The following is a description of a gene set: species: Mus musculus Mouse Gene Set: GOBP_REGULATION_OF_SYNAPTIC_PLASTICITY A process that modulates synaptic plasticity, the ability of synapses to change as circumstances require. They may alter function, such as increasing or decreasing their sensitivity, or they may increase or decrease in actual numbers., and this is the list of marker genes: Shisa6 (NCBI Gene Id 380702), Mirlet7d (NCBI Gene Id 387247), Serpine2, Grid2, Cc2d1a, Mir487b, Rara, Rims1, Grin2d, Cntn2, Mylk2, Atf4, Mir7b, Vgf, Sct, Ntrk2, Adora2a, Mir19a, Adcy8, Shisa7, Gria3, Abl1, Mir384, Mir150, Gip, Brsk1, Ppfia3, Rab3gap1, Kcnq3, Grm5, Nr3c1, Rab3a, Pirb, Gnal, Mir221, Map1b, Arf1, Enpp1, Psen1, Htr6, Mir673, App, Fxr2, Mir500, Kmt2a, Mir672, Kcnb1, Mir667, Mir320, Grin1, Slc38a1, Grin2a, Star, Ythdf1, Mir410, Jph3, Mir125b-2, Mir381, Mir433, Syn1, Kcnq2, Mir467a-1, Atp2b2 (NCBI Gene Id 22426), Mir30b, Mir125b-1, Mir126a, Mirlet7e, Mir138-2, Mir24-1 (microRNA 24-1), Mir101b, Ace, Iqsec2, Lnpep, Cd38, Mir134, Prkcg, Abhd6, Hrh1, Acp4, Snap25, Hras, Shank3, Plk2, Camk2b, 2510002D24Rik, Mir301b, Cpeb3, Cbln1, Stau2, Grin3b, Syt4, Grip1, Syp, Mir92-1, Lypd6, Mir467a-7, Mir106b, Camk2d, Mir28a, Mir30e, Sipa1l1, Mirlet7i, Zzef1, Pmch, Grik1, Neto1, Mir92-2, Mef2c (myocyte enhancer factor 2C), Mir26a-2, Mir23a, Mir26b, Ager, Stau1, Mir19b-1, Mecp2, Htt, Mir30a, Mir22, Rin1, Kit, Mir540, Mir324, Mir211, Mir9-3, Rasgrf2, Mir467a-3, Alg13, Ephb2, Mir181d, Syap1, Mir486, Mir151, Cln3, Rgs14, Mir125a, Stxbp1, Slc18a3, Ywhag, Mir421, Mir127, Adora1, Mir106a, Mir98, Fgf14, Mir181b-2, Cx3cr1, Rab8a, Mir411, Gria1, Crtc1, Prkar1b, Mir29b-1, Bcl2l1, Ncdn, Dgki, Mirlet7f-2, Igsf11, Adrb1, Lzts1, Mir19b-2, Mir378a, Nlgn1, Chrdl1, Eif2ak4, Rac1, Zdhhc2, Ncstn, Mir744, Psen2, Sqstm1, Shank2, Drd1, Mir181a-1, Mir760, Ctnnd2, Ptpn5, Gipc1, Eif4ebp2, Pten, Nr2e1, Mir9-1, Bace1, Vamp2, Egr2, Creb1, Drd5, Nsg1, Pde9a, Mir222, Snca, Mir467a-9, Egr1, Mir101a, Grin3a, Musk, Nf1, Fcgr2b, Grin2b, Htr7, Chrd, Mir181c, Mir383, Itpka, Mir218-1, F2r, Mir25, Mir467a-5, Dlg4, Grik2, Mir7-1 (NCBI Gene Id 723902), Mir30c-1, Mir149, Mir92b, Mir129-2, Prrt2, Baiap2, Anapc2, Mir345, Mir7-2, Crhr1, Mir99a, Kcnn2, Mir1983, Reln, Spg11, Camk2g, Mir29a, Mir467a-8, Kcnj10, Unc13b, Gfap, Grin2c, Mir130a, Chrna2, Stx3, Mir467a-6 (NCBI Gene Id 100526537), Snap47, Neurod2, Cpeb1, Mir467a-4, Mir330, Calb1, Mir129-1, Mir328, Grm2 (glutamate receptor, metabotropic 2), Mpp2, Mir872, Adgrb1, Tnr, Mir30c-2, Lgmn, Ppp1r9a, Rapgef2, Nlgn3, Tyrobp, Slc8a3, Rasgrf1, Mir337, Mir30d, Large1, Shisa8, Synpo, Arc, Mir425 (NCBI Gene Id 723864), Mir652, Mir17, Slc1a1, Jph4, Rab5a, Hnrnpk, Itpr3, Mir132, Rab11a, Mir153, Mir24-2, Ptk2b, Nrgn, Mir204, Neurl1a, Cdk5, Atp1a3, Mir137, Pak1, Tshz3, Mir9-2, Akap5, Mir187, Mir467b, Agt, Ssh1, Mir29b-2, Mgll, Mir148b, Kdr, Grid1 (NCBI Gene Id 14803), Mir338, Mir342, Mir539, Mir128-1, Mir434, Slitrk4, Prkcz, Fxr1, Fam107a, Mir467a-10, Mir181a-2, Crh, Mmp9, Mir124a-1hg (Mir124-1 host gene (non-protein coding)), Syngap1, Mir382, Unc13a, Sorcs2, Mir195a, Mir100, Mirlet7c-1, Mir379, Slc8a2 (solute carrier family 8 (sodium/calcium exchanger), member 2), Mir674, Pick1, Myo6, Cyp46a1, Srf, Mir124-2hg, Ckap5, Mir26a-1, Mir93, Kat2a, Mir374b, Mir191, Mirlet7f-1, Mir551b, Penk, Kras, Braf, Epha4, Vps13a, Mir218-2, Prnp, Mir541, Cd2ap, Paip2, Syt12, Nog, Unc13c, Sctr, Hrh2 (histamine receptor H2), Apoe, Hmgcr, Nfatc4, Chrna7, Mir181b-1, Mir501 (NCBI Gene Id 751560), Calhm2, Prrt1, Sorcs3, Slc24a2, Lrrtm2, Cfl1, Mir138-1, Mir467a-2, Crhr2, Bdnf (brain derived neurotrophic factor), Cdc20, Adcy1, Map1a, Nos1, Mir369, Lrrtm1, Syt7, Camk2a (NCBI Gene Id 98128), Mir770, Mapt, Slc4a10, Mir145a, Mme, Syngr1, Gsk3b, Mir20a, Stx4a, Mirlet7c-2, Ptgs2, Gsg1l, Dag1, Nsmf, Mir128-2, Best1, Dbn1, Dbi, Mir15a, P2rx3, Cplx2, Mir23b, S100b, Slc24a1, Grid2ip, Mir484, Drd2, Ube3a, Nptn, Ptn, Mir300, Shisa9, Npas4, Fmr1, Mapk1